Given this list of marker genes Ferd3l (Fer3 like bHLH transcription factor), Cluap1, Dzip1l, Cobl, Cby1, Cdk20, Foxb1, Gli2 (GLI-Kruppel family member GLI2), Stil, Nodal, here is a description of the gene set: studied in species Mus musculus The progression of the floor plate over time from its initial formation until its mature state. Mouse Gene Set: GOBP_FLOOR_PLATE_DEVELOPMENT